Given this list of marker genes UBE2H, QKI (QKI, KH domain containing RNA binding), SMAD3, NDEL1, CBFB, ATAD2, RASSF9, RASA3, DHX15, RGS10, CORO7, SLC25A46, FCHO2, LEPROT, EXOC2, MEIS2, PIGQ, TUBA8, FBXO5, RSPRY1, TRAPPC8, TAX1BP3, SERINC1, MTHFD2L, CDC42SE1, HNRNPLL, RAB8B, PROX2, NFATC2IP, LSM14A, ZDHHC8 (zinc finger DHHC-type palmitoyltransferase 8), PITPNC1, TAFA3, ZFP1, GAPVD1, CRISPLD2, CTTN, RTN3, ARFGAP2, MAOB, IFI35, SLAIN2, LPCAT1 (NCBI Gene Id 79888), ERN1, KDM1A, PARD6G, MTMR7, GABRB1, SNORD89, ENTREP3, STEEP1, PLEKHG2, IL24, TM9SF3, IGF1R, RGL2, ENO4, NIN, AIM2, DLL3, FEN1, STYXL2, FCHSD2, NPTX1 (neuronal pentraxin 1), BUB3, AAMDC, BASP1, MBNL2, LRIG1, SLK, BICD2, TMEM127, SCAF8 (SR-related CTD associated factor 8), CTNNB1, ZMIZ1, DYNC1I2, RNF139, TAGAP, AKT3, GPRASP2, XXYLT1, PTCH1, HBEGF, TBC1D15, CPNE3, WASHC4, MANEA (NCBI Gene Id 79694), NCKAP1L (NCBI Gene Id 3071), EREG, FAM90A13, TES, KRAS, PCGF3, IFT43, ZNF583, SLC10A7 (solute carrier family 10 member 7), RGS12, RAD18, HTT, AXIN2, KCNN4, CD83, GSN (gelsolin), SPRED1, KAT2B, CNPPD1, LY6K, SUSD6, HMGB3, GPR160, ATE1, SLC4A7, ST6GAL2, TP53INP1, STX1A, UBE2B, CTNNA1, PIK3R5, PITPNM1, GAST, BNIP5 (NCBI Gene Id 389384), ULK2, GRN (NCBI Gene Id 2896), SCN3B, IPO8, ATG4A, KLF9, PPP4R2, RAP1A, CUX1, SNX13, ACSL3 (NCBI Gene Id 55484), ATP2C1, IQGAP1, STXBP3, PAK2 (NCBI Gene Id 9106), TERB2, SEC24A, GFRA2, AP1AR, SKIL (NCBI Gene Id 6498), FNBP1L, LAMP1, HSF5, SLC25A40, UGCG, SLC13A1, PYGL, SLC9B2, TENT5C (terminal nucleotidyltransferase 5C), CLCC1, SDCBP2, TGFBR2, FBXL5, MCFD2, KBTBD2, AKIRIN1, CD226, DNAH6, LYST, EEIG2 (NCBI Gene Id 284611), SRP54, MFSD12, RNF133, CUL4B, BEND7, GALNT1, SS18, VPS26A (VPS26 retromer complex component A), CYRIA, RDX, MFSD11, UBQLN1, BTBD7, ZNF318, SLC39A6, UCN2, PTPRZ1, ATF7, LPGAT1, ZEB1, ATL2, AKAP13, RIC8B, ENPP4 (NCBI Gene Id 57011), PHAF1, RBM5, FBXO11, CNTD1, CADM2, TMEM65, ATXN10, BMPR2, ANXA3, CCR6, CASR, PRKCB, ARHGEF40, TMEM52B, here is a description of the gene set: TGF-beta3 produced by developing Th17 cells induces highly pathogenic T cells that are functionally and molecularly distinct from TGF-beta1-induced Th17 cells. The microarray data represent a distinct molecular signature for pathogenic versus non-pathogenic Th17 cells. Human Gene Set: GSE39820_TGFBETA3_IL6_VS_TGFBETA3_IL6_IL23A_TREATED_CD4_TCELL_UP Genes up-regulated in comparison of CD4 T cells treated with TGFB3 and IL6 versus those treated with TGF3B, IL6 and IL23A. species: Homo sapiens from publication Lee Y, Awasthi A, Yosef N, Quintana FJ, Xiao S, Peters A, Wu C, Kleinewietfeld M, Kunder S, Hafler DA, Sobel RA, Regev A, Kuchroo VK (PMID 22961052)